The following is a description of a gene set: Human Gene Set: HP_ABNORMALITY_OF_THE_HYPOTHALAMUS_PITUITARY_AXIS studied in species Homo sapiens Abnormality of the pituitary gland (also known as hypophysis), which is an endocrine gland that protrudes from the bottom of the hypothalamus at the base of the brain. The pituitary gland secretes the hormones ACTH, TSH, PRL, GH, endorphins, FSH, LH, oxytocin, and antidiuretic hormone. The secretion of hormones from the anterior pituitary is under the strict control of hypothalamic hormones, and the posterior pituitary is essentially an extension of the hypothalamus, so that hypothalamus and pituitary gland may be regarded as a functional unit. Abnormality of the hypothalamus-pituitary axis, and this is the list of marker genes: MEIOB, NUP107, POU1F1, KDM1A, TOGARAM1, UBE2T, PRKAR1A, USP8, PIBF1, GATA4, HPGD, ARNT2, RBM28, NPHP1, PTCH1 (NCBI Gene Id 8015), SEMA3A, MLH1, FANCA, TBX3, MEN1, AHI1, PROP1, FBXO43, PUF60, IFT74, SRY, HLA-DPB1, STAT5B, ALMS1, TP53, ARL13B, BMP15, B3GLCT, MSTO1, KDM6A, CSPP1, PALB2, HROB, TBX2, OFD1, USP48 (ubiquitin specific peptidase 48), KRAS, NDN, TRAF7, THOC2, DIAPH2, NDNF, ZIC2, GDF9, WDR4, ZMYND15, IGSF1, BMP4, FARSA, CHD7, MCM9 (minichromosome maintenance 9 homologous recombination repair factor), BRCA2, EIF2S3, MSH6, DBH, B9D2, CDKN1B, MAGEL2, CDH23, TMCO1, MSH2 (NCBI Gene Id 8169), EDA2R, FOXA2, SLC30A7, PDGFB, PSMC3IP, BMPR1B, APOA5, BMPR1A, ABCD1, DNAH10, NR5A1, NKX2-1, RNF216, SIM1, CLPP, FKBP6 (NCBI Gene Id 8468), DNAJB11, FIGLA, ESR1, TACR3, CYP11A1, CBY1, EFL1, GHRHR, CT55, SOX2, GLI2, LHCGR, KANSL1, PWRN1, NODAL, OTX2, DUSP6, FSHR, CRIPTO, CDKN2B, MAD2L2, TSC2 (NCBI Gene Id 7249), SIN3A, TBCK, FANCM, HERC2, PDE6D, ADAT3 (adenosine deaminase tRNA specific 3), PREPL, FANCG, FLNB (filamin B), ANK1, PRLR, OCA2, TMEM138, PROKR2, BRAF, NSUN2, BTK, NPAP1, NONO, EDA, SMAD2, IFT56, BNC1, GATA6, CFTR, FANCL, SOHLH1, MT-ATP8, VANGL2, GMNN, PNPLA6, ACP5, SBDS, CTNNB1, SLC29A3, TEX15, FMR1, SNORD115-1, LZTR1, RPL10L, FOXH1, TGFBR2, TMEM237, HESX1, KASH5, PWAR1, LEP, MAST3, PIK3CA, C14orf39, ALX3, CDKN2C, CDKN1A, ERCC4, FANCE, GPR161, PSMD12, RNF212, MAP3K1, CPLANE1, LHX3, MSH4, ALG9, TERT (NCBI Gene Id 7015), ERCC6, COQ6, GH1, DMXL2, MKRN3, MPDU1, DHX37, TMEM218, ADNP, IGF2, FGFR1, KMT2D, SYCE1, GNAS, TRHR (thyrotropin releasing hormone receptor), AR (androgen receptor), IFNG, KCNJ11, FOXL2, MT-TL1, IFT140, CTSK, SMO, MUTYH, CEP104, TGIF1, DLL1 (NCBI Gene Id 28514), WASHC5, MTHFR (NCBI Gene Id 4524), HID1, NR0B1, TMEM231, SOX10, CC2D2A, FGD1, HFM1, KIAA0753, MED12, MCM4, RNPC3, RNF113A, BAP1, PMM2, ZFPM2, RPGRIP1L, TBX19, ZNF462, RNU4-2, SLC7A7, MOV10L1, TMEM216, YY1, POLD1, ARMC9, MANF, PROK2, EPCAM, IGF1, CTLA4, KATNIP, PITX2, TDRD9, GAN, PDHA2, CHEK2, NF2, TERB1, POLA1, SHOC1 (shortage in chiasmata 1), FANCB, GPR101, PRTN3, SLX4 (SLX4 structure-specific endonuclease subunit), STAG2, BRCA1, IDH1, TCTN3, NANOS1, TEX11, SEMA4A, RAD51, B9D1, ESR2, FANCD2, DYRK1A, WDR11, TMEM67, IL17RD (interleukin 17 receptor D), ZNF423, CBX2 (NCBI Gene Id 876), IARS2, SLCO2A1, SPIDR, TAF4B, HSD3B2, AKT1, WWOX, HBB, ARL3, SIX6, SIX3, VAMP7, STX16, CNBP, SPRY4, RRM2B, CDKN1C, FANCF, BRIP1, XRCC2 (NCBI Gene Id 7516), SMC1A, TCTN1, KIAA0586, ZNRF3, ATRX, DHH (NCBI Gene Id 791256), PTDSS1, IDH2, BRCC3, ERF, FLRT3, POLE, HLA-DPA1, TRH, CCDC34, LEPR, STIL, RPS20, SPAG17, SRD5A3, ESCO2, DNAJC21, LHX4, PUS1, DDC, GAS1, LIG4, PCSK1, GNB2, FANCC, MSH5, CEP290, POMC, POLR3H, GRB10, TEX14, CEP57, AIP, SEMA3E, IKBKG, GCNA, CATIP, SRPX2, SPATA22, ZSWIM7, MAP2K2 (NCBI Gene Id 85511), SYCP3, STEAP3, SOX9, LARS2, RRAS2, FSHB, NFKBIA (NCBI Gene Id 4792), POLR3GL, NR3C1, CDKN2A, NSMCE2, STAG3, ZFX, KMT2A, SHH, DCC, PTPN22, ROBO1, TSHB, GANAB, VPS13B, CDON, RFWD3, RAD51C, SNORD116-1, TP63, SUFU, DISP1, FEZF1, VSX1, GHSR, SOX11, PI4KA, PLCH1, ZNF148 (NCBI Gene Id 7707), FGF8, CEP120, BPTF, CDC42BPB, GLI3 (GLI family zinc finger 3), SYCP2L, ATM, CYB5A, GRM7, SMARCB1, BICC1, AFF4, LHB, POR (NCBI Gene Id 96440), PKD2, KISS1R, PPP2R3C, DNHD1, HSD17B4, CYP17A1, ZSWIM6, HS6ST1, PKD1, MCM8, INPP5E, TBCE, ADGRG1, HYLS1, MRPS22, KLHL10, ARMC5, CCDC141, SNRPN, MADD, POLR3A, TCTN2, SOX3, CEP41, POU3F4, NDE1, COG2, MKS1, SMARCE1, TERB2, FOXC1, FANCI, FGF17 (fibroblast growth factor 17), ANOS1, PNLDC1, APC, WT1, NFKB2, AXIN1, PMS1, ALG5, PDE11A, TSC1, PMS2